The following is a description of a gene set: The directed movement of thiamine into, out of or within a cell, or between cells, by means of some agent such as a transporter or pore. Thiamine is vitamin B1, a water soluble vitamin present in fresh vegetables and meats, especially liver. Mouse Gene Set: GOBP_THIAMINE_TRANSPORT studied in species Mus musculus, and this is the list of marker genes: Slc19a3, Slc47a1, Slc22a1, Slc25a19, Slc19a2, Slc44a4, Slc22a2, Slc35f3